The following is a description of a gene set: Genes up-regulated in atherosclerosis macrophages: control anti miR ctrl versus untreated. studied in species Homo sapiens from publication Rayner KJ, Sheedy FJ, Esau CC, Hussain FN, Temel RE, Parathath S, van Gils JM, Rayner AJ, Chang AN, Suarez Y, Fernandez-Hernando C, Fisher EA, Moore KJ (PMID 21646721) Inhibition of miR-33 results in increased cholesterol efflux and HDL-cholesterol levels in mice. In this study we examined the effect of miR-33 inhibition in a mouse model of atherosclerosis and observed significant reduction in atherosclerotic plaque size. At the end of the study, gene expression in macrophages from the atherosclerotic plaques was assessed. The results demonstrated a reduction in inflammatory gene expression and increased levels of mRNAs containing miR-33 binding sites. Human Gene Set: GSE28783_CTRL_ANTI_MIR_VS_UNTREATED_ATHEROSCLEROSIS_MACROPHAGE_UP, and this is the list of marker genes: S100A12, SYCP1, CDR1, RCAN2, PAN2, AUTS2, GPR107, CD69, TACR3, COASY, LASP1 (NCBI Gene Id 3927), IST1, SIGLEC6, ABCC2, RPS12, VAC14, GPX4, PAH, CNTNAP2, EI24, ZFP36L1, PIGK, CRYBG3 (crystallin beta-gamma domain containing 3), SMG6, ADAM20, FAP, ZNF423, H3-3B (H3.3 histone B), GPC4, DDX39B, IRF8, CYP1B1, PHKG1, LCP1, TADA3 (transcriptional adaptor 3), ARAF, BRDT (bromodomain testis associated), THBS3, DMD, SMARCC2, APBB1, RASSF9, GRM7, CRISP1, KCNN3, NUP58, PPP2R5A, HSDL2, DYNLT1, DIO1, SLA, CCL16, CRIPTO, POFUT2, RPL24, DCAF11, LPCAT4, DLGAP5, CXCL13, CCDC181, TSPAN8, TAF10, DSC3, CTBP1, PDXDC1, DLC1, ARPC2, FLT1, SRSF6, KATNIP, MYC, ALDH1B1, MED13, GAS7, MGAM, IGFBP5, SFT2D2, PTEN, MAGEA10, TCAF1, SIK3, ANKRD6, MNAT1, NEFL, RBM3, KIAA0087, MEIS1, TMCO6, PPARG, RLN2, SH3GL2, ASAH1, NFKBIE, ELP4, KHDRBS1, PENK (NCBI Gene Id 5179), SULT1A1, ESM1, LIPC, TEX41, MEST, NDUFS8, TAF11, TMEM11, CYP7A1, CUL4A, WIPF2 (NCBI Gene Id 162601), PCCB, CDKN3, SMARCE1, GOLGA8A, ARFIP2, AKAP5, NDUFA7 (NCBI Gene Id 4701), PLA2G4A, ACTR1B, TWF2, MYBL2, CFL1, ZPBP, LPXN, IL12B, JOSD1, GYPB, GNRH1 (gonadotropin releasing hormone 1), SSX1, RGS16, KIAA1549L, POU2F2, CT62, FABP2, CHGB, ETFDH, CRIP1, INPP5B, MEN1, POLR1F, TSC1, UBE3A, CNOT9, PI4KB, SLC5A12, RBM17, HLA-DRB6, RRP8, BHLHE40, C4BPA, TCF4, FLOT1, ARPC1A, CCR8, R3HCC1, WDFY3, ROS1, NEFH, PELP1, CD72, SURF2, CTH, RAD23A, TCOF1, FGF7, ZNF207, RPE65, EPM2AIP1, APOOL, MAGEA12, COG4, ZNF518A, HBD, TAP1 (transporter 1, ATP binding cassette subfamily B member), PLAAT3, ENDOD1, WIF1, VCAN, GSS, MCL1, SLC22A2, SMS, RPL36A, PRG4, BCAT2, ZBTB16, ZBTB39, ZNF204P, KLRG1, RAD51C, SDC4, PEX12, PNLIPRP2, ATOX1, H2BC12, CYLD, EREG, PRKN, CYP2B7P, DLD, EIF1B, CCL4